Given this list of marker genes PARP15, TSHZ3 (teashirt zinc finger homeobox 3), FBXO36, BTNL8, PDZD2, ASPH, ACACA, DDIT3, MYO19, AOC3, RELN (reelin), POU5F1B, ALDH6A1 (NCBI Gene Id 4329), POU5F1, MUC7, ACAN, ANKRD49, RNF123, ERMN, USP3, MMP25, PUS7L, KCNB1, AP1G1, TMEM221, POLDIP2, UBE2H, ELAVL1, RAG2, H6PD, TRDMT1, ABI2, CYP8B1, BLOC1S5, TMEM41B, NXPE1, FAM131B, SLC25A23, MARCHF7, DNAJA2, DBT, KIF13A, ROBO2, USP48, ENSG00000255537, PIK3AP1, SLC28A1 (solute carrier family 28 member 1), OSER1, PAXBP1, MEF2C, ZNF107, HSF2BP, COL19A1, here is a description of the gene set: from publication Chen Y, Wang X (PMID 31504780) Human Gene Set: MIR4654 species: Homo sapiens Genes predicted to be targets of miRBase v22 microRNA hsa-miR-4654 in miRDB v6.0 with MirTarget v4 prediction scores > 80 (high confidence targets).